Given this list of marker genes PRPF38A, DPF2, ETFA, CBX4, SPRYD7, MTARC2, IL15RA, TMCC3, CCL4, SCIN, CDKN2A, CDC73, BIRC6, SERPINF1, MCL1, SPOP, CHST15, ATP10A, PIK3R1, RND3, NMT2, EIF5B, NLGN2, NFKBIL1, STAT3, SERINC1, MAPK6, CASP1, RBM43, KMT2A, APBB2, GATAD2A, MDM2, STARD3, DDIT4, SEC14L1, RNGTT, PRNP, SLC6A4, IL7R, BCKDHB, ASPH, LRRC4, P4HA2, TNFRSF1A, BARX1, TLR8, MAP3K8, ARID4B, FOXJ2, GBGT1, NFKBIZ, NECAP1, RNF135, RIPK1 (receptor interacting serine/threonine kinase 1), TCAF2, TMEM184B, CUTC, PGLYRP1, AP3M2, PLEKHN1, CA13, IDNK, LYN, DYNC1I2, ASB11, SLC43A3, PLPP3, ARHGAP24, LAPTM4A, STX4, PRPF38B, DUSP2, POLR3C, C5orf47, SFXN2, MSL1, AFF1, ENPP4, RSBN1, FBH1, ZFP36, IL2RA, TMTC4, UBE2R2, TRAPPC14, TBC1D1, CLRN3, BRCA1 (BRCA1 DNA repair associated), RAB9A, AP3B1, PARP3, PCDHA12, RBL1, GRN, TLE4, ETAA1, SPATS2, CLN8, ABCG1, CA6, ANKIB1, PIAS1, TMEM183A, RUFY3, ALPK2, CMTR1, CYLC1, ZCCHC3, DNAJC14, RAD21, TMEM209, CD84, CCRL2, ETNK1, RFFL, TAX1BP1, CCR2, DOK2, DDIT3, USB1, MRPL13, ATP11B, KCTD10 (NCBI Gene Id 83892), NRDE2, UBE2D2, EMC8, CAAP1, PI4K2B, CELA1, XPO6, SCT, SYT4, GCNT2, CLASP2, RPE, PSME4, ZCCHC8, PRDM4, SLFN13, MAN2A1, SMAGP, RNF115, NRBP1, CUL4B, RAB33B, UBE2D1, RMDN3, FYB1, ARMCX3, ARHGAP12, NCOA6, PSME2, NAA20, TLK2, TRIL, GBP4, RNPEP, MBD4, TBC1D13, SERTAD3, TUBGCP3, UPP1, PCDH15, RC3H2, RGS2, DDX24, MYBPC3, PSAT1, TMEM131, NFATC1, TMEM168, NR1I3, OTUD5, ARL6IP1, ITGB1, RANBP9, IFT172, CHMP4B, SDCBP, COX18, TRIM26, PARP12, FOSB, TNKS2, KCNJ5, DGKA, XRN1, RGS14, RASA2, C6orf62, IGKC, SLC9A1, CHAC2, PDCL, TOB2, FIGNL1, TOX4, ZNF362, NUB1, here is a description of the gene set: species: Homo sapiens mouse primary BMDCs were stimulated with tlr ligands and gene expression changes were profiled on Affymetrix arrays Genes down-regulated in comparison of dendritic cells (DC) stimulated with Pam3Csk4 (TLR1/2 agonist) at 8 h versus DC cells stimulated with Gardiquimod (TLR7 agonist) at 8 h. Human Gene Set: GSE17721_PAM3CSK4_VS_GADIQUIMOD_8H_BMDC_DN from publication Amit I, Garber M, Chevrier N, Leite AP, Donner Y, Eisenhaure T, Guttman M, Grenier JK, Li W, Zuk O, Schubert LA, Birditt B, Shay T, Goren A, Zhang X, Smith Z, Deering R, McDonald RC, Cabili M, Bernstein BE, Rinn JL, Meissner A, Root DE, Hacohen N, Regev A (PMID 19729616)